Given this list of marker genes PHF11, EBPL, MIR15A, NF1, FNDC3A, MIR34A, OMG, CDKN2A, ATAD1, RERE, SPSB1, PRKN, KCNRG, H6PD, SPRYD7, FAF1, CDADC1 (cytidine and dCMP deaminase domain containing 1), TRIM13, QKI, SETDB2, RCBTB2, RB1, SLC45A1, EVI2B, RCBTB1, CDKN2B, PTEN, KPNA3, ENO1, CDKN2C, CAB39L, here is a description of the gene set: from publication Cancer Genome Atlas Research Network (PMID 18772890) species: Homo sapiens Human Gene Set: TCGA_GLIOBLASTOMA_COPY_NUMBER_DN Human cancer cells typically harbour multiple chromosomal aberrations, nucleotide substitutions and epigenetic modifications that drive malignant transformation. The Cancer Genome Atlas (TCGA) pilot project aims to assess the value of large-scale multi-dimensional analysis of these molecular characteristics in human cancer and to provide the data rapidly to the research community. Here we report the interim integrative analysis of DNA copy number, gene expression and DNA methylation aberrations in 206 glioblastomas--the most common type of adult brain cancer--and nucleotide sequence aberrations in 91 of the 206 glioblastomas. This analysis provides new insights into the roles of ERBB2, NF1 and TP53, uncovers frequent mutations of the phosphatidylinositol-3-OH kinase regulatory subunit gene PIK3R1, and provides a network view of the pathways altered in the development of glioblastoma. Furthermore, integration of mutation, DNA methylation and clinical treatment data reveals a link between MGMT promoter methylation and a hypermutator phenotype consequent to mismatch repair deficiency in treated glioblastomas, an observation with potential clinical implications. Together, these findings establish the feasibility and power of TCGA, demonstrating that it can rapidly expand knowledge of the molecular basis of cancer. Genes down-regulated and displaying decreased copy number in glioblastoma samples.